Given this list of marker genes POLQ, FIGNL1, TFRC, CHTF18, TCP1, XRCC5, GTPBP4, ERCC1, GZMA, METTL4, FOXP3, MCIDAS, HTR2A, UIMC1, EID3, TADA1, BCL7B, C11orf54, PDGFRB, FGF10, GNL3, FUS, ATRX, KAT7 (NCBI Gene Id 63437), NUDT16L1, ENDOG, ATF1, MYC, SMCHD1, EREG, XRCC1, MGMT, SMARCB1, SETMAR, LIG3, TAF12, HCRT, UCN (NCBI Gene Id 7349), FMN2, SLX1A, SLX1B, DFFA (NCBI Gene Id 1676), STAT6, SPIRE1, EPC2, ATRIP, MAPK15, CDC7, PARP3, ARID1B, PLK1, NMNAT1, ENY2, SMG5, ZCWPW1, SIRT6, MAGEF1, RFC3, WEE1, FGFR4, SENP3, SF3B5, SUPT7L (NCBI Gene Id 9913), USP22, RUVBL1, RIF1, TADA3, SLFN11 (schlafen family member 11), SMARCAD1, POLG2, SMG6, PPP4R3B (protein phosphatase 4 regulatory subunit 3B), SETD7, ERCC2, RBBP6, PMS2, PRDM9, SIRT1, PNKP, ATM, TAF6L, SUPT6H, SMC3, INO80, SGF29, HMGA2, TAF7, EYA2, WAS, ZSCAN4, ZBTB38, CIZ1, TRIM28, PAXIP1, GLI2, ZNF365, ABL1, GDF2, AURKB, PRKCQ, NFRKB, ACTL6B, HMGB1, DCP2, H1-10, NDFIP1, FAF1, H1-4, KMT5B, AXIN2 (axin 2), CCT2 (NCBI Gene Id 10576), ACTR2 (actin related protein 2), GMNC, CDKN1B, GATA5, MCM5, SMARCD1, EYA3 (EYA transcriptional coactivator and phosphatase 3), FANCB, CD28, BRPF3, STK19, TNFAIP1, NAT10, FBXO4, DKC1, TTF1, SMARCA5, MAPK3, MAP2K7, KDM1A, PARP1, PARPBP, PDGFB, NBN, ERCC6, PRKCG, CCT3, BRCC3, ANKRD17, DBF4B, PRKCD, WRNIP1, YY1, VEGFA, CCDC117 (coiled-coil domain containing 117), H1-2, CYREN, RMI2, TFPT, STN1, SLF1 (SMC5-SMC6 complex localization factor 1), CCT4, ORC3, RAD17, OTUB1, CCT5, ARID1A (AT-rich interaction domain 1A), POLH, KAT5, UBE2V1, CHTF8, DMAP1, BRD8, YEATS4, TNFSF13 (TNF superfamily member 13), MBTD1, NPPC, SF3B3, CCT7, HNRNPU, H1-1, WAPL, PINX1, SUV39H1, RFC2, KDM4D, ENPP7, NSMCE3, E2F7, MCM7 (NCBI Gene Id 4176), POLE3, ACTB, SRC, H1-9P, PARN, PPP4C, SMG1, GNL3L, ESCO2, E2F8, DFFB, ANKRD31, ZMPSTE24, TEN1, TERF1, UPF1, SH2B1, SIRT7 (NCBI Gene Id 51547), PPP4R2, SENP2, HELQ, NVL, AGER, PIF1, NSMCE2 (NCBI Gene Id 286053), CREBBP, BAZ1A, PRKDC (protein kinase, DNA-activated, catalytic subunit), MPV17, DNA2, PRMT1, PTK6, HNRNPD, MORF4L1, H2AX, CCT8, PRKD2, TIPIN, CAMSAP3, PCNA, UCHL5, YLPM1, MSH3, ID3, EPC1, PPP1R10 (protein phosphatase 1 regulatory subunit 10), EP400, TSPYL2, TWIST1, SLF2, HSF1, MCM3, RNF8, TNF, BABAM1 (BRISC and BRCA1 A complex member 1), KLF4, ING4, AKT1, EYA4, MCRS1, TENT4B (NCBI Gene Id 64282), JADE1, TGFB1, USP7, SHLD2, DPF2, TFIP11, CGAS, CCNA2, H1-8, ERCC8, ACTL6A, OBI1, USP1, SMC5, IER3, TNKS, TIGAR, TP53BP1, BCL7A, BLM (NCBI Gene Id 641), TEX15, HGF, TAF4, NEK7, PBRM1, UBE2N, CDK2, SLC15A4, MRE11, MAPK1, SHLD1, TRRAP, ANKLE1, SMARCE1, RECQL5, BAX, CCT6A, PDS5A, RAD52, FGFR1, IL27RA, TAF6, CD40 (NCBI Gene Id 958), WDR48, MAPKAPK5, IL10, INO80B, PIAS4, ABRAXAS1, CSNK2A1, TMEM161A, ATR, KPNA2, BRCA1, MCM4, KAT2B, CTC1, UBQLN4, KPNA1, FBH1, RPS3, KMT5C, H1-0, SETD2, ING3, RAD51, ACTR5, SMOC2, RNF169, PTGES3, C1QBP, CDK9, VPS72, NSD2, CEBPG, APLF, SUPT3H, RNF168, CDT1, DHX9, S100A11, CUL4A, ADIPOQ, USP51, CIDEA, PTPRC, MARCHF6-DT, ERCC4, POT1, NAF1, H1-5, RAD51AP1, TBX21, SUB1, TIMELESS, IL2, SPIRE2, SMARCC1, BCL6, NUGGC, RAD50, WRN (WRN RecQ like helicase), MRNIP, NOX4, WIZ, KHDC3L, H1-6, NEK2, DPF3, AICDA, H1-3, SMARCD2, TINF2, PPP4R3C, FH, SMARCD3, TNFSF4, PELI1, APAF1, NSMCE1, PML, TICRR, DDX11, ORC5 (origin recognition complex subunit 5), MCM2, XRN1, CTNNB1, EGFR, PDGFA (platelet derived growth factor subunit A), IL6, SMARCA4, KAT2A, TFDP1, RTEL1, SMARCA2, RNF126, CLCF1, MCM6, STOX1, ARID2, FOXM1, NSMCE4A, RUVBL2, KCNK2, KMT5A, TAF5L, IL4, TAF2, DUSP1, HDAC10, SMARCC2, FAM168A, FGF2, CDKN1A, HELB, SPIDR, HDGFL2, TOM1L1, LMNA, DSCC1, PARG, PKIB, OGG1, HDAC8, NIBAN2, SLX4, AUNIP, ACTR8, MLH1, ING5, TAF5, ANKRD1, JADE3, CHRAC1, MAP3K4, CBX8, CDK1, ATXN7L3, NUCKS1, MRGBP, KLHL15, HMCES (NCBI Gene Id 56941), DACH1, NPM2 (nucleophosmin/nucleoplasmin 2), CHEK1, CDC25A, BARD1, RGCC, PPP4R3A, CACYBP, DHX36, GLI1, INO80D, MIR221, SHLD3, EXOSC3, TAF9, INO80C, EXOSC10, ATAD5, SMC6, TOP2B, MSH6, HNRNPC, UBE2V2, RPA2, DPF1, NABP2, TNKS2, DBF4, EYA1, ACD, FBXO5, UBE2B, HNRNPA2B1, EHMT2, DNAJC2, MSH2, SUPT20H, H1-7, TERF2IP, USP37, JADE2, BABAM2, MAD2L2, BCL7C, DEK, TERF2, GMNN, OOEP, TAF10, SSBP1, TADA2B, WRAP53, RFC4, INO80E, CDC6, EXOSC6, ESCO1, HSP90AA1 (NCBI Gene Id 89272), ACVRL1, NPAS2, HNRNPA1, ATXN7, TP53, DYNLL1, KCTD13, MEAF6, RFC5, IL7R, RADX, SKP2, RIOX1, MORF4L2, BRD7, PHF10, here is a description of the gene set: Human Gene Set: GOBP_REGULATION_OF_DNA_METABOLIC_PROCESS studied in species Homo sapiens Any process that modulates the frequency, rate or extent of the chemical reactions and pathways involving DNA.